The following is a description of a gene set: from publication Wakim LM, Woodward-Davis A, Liu R, Hu Y, Villadangos J, Smyth G, Bevan MJ (PMID 22922816) Genes down-regulated in memory CD8 T cells: ITGAE- from spleen versus ITGAE+ from brain. Tissue resident memory (Trm) represent a newly described memory T cell population. We have previously characterized a population of Trm that persists within the brain following acute virus infection. Although capable of providing marked protection against a subsequent local challenge, brain Trm do not undergo recall expansion following dissociation from the tissue. Furthermore, these Trm do not depend on the same survival factors as the circulating memory T cell pool as assessed either in vivo or in vitro. To gain greater insight into this population of cells we compared the gene-expression profiles of Trm isolated from the brain to circulating memory T cells isolated from the spleen following an acute virus infection. Trm displayed altered expression of genes involved in chemotaxis, expressed a distinct set of transcription factors and overexpressed several inhibitory receptors. Cumulatively, these data indicates that Trm are a distinct memory T cell population disconnected from the circulating memory T cell pool and displaying a unique molecular signature which likely results in optimal survival and function within their local environment. species: Homo sapiens Human Gene Set: GSE39152_SPLEEN_CD103_NEG_VS_BRAIN_CD103_POS_MEMORY_CD8_TCELL_DN, and this is the list of marker genes: MAFF (MAF bZIP transcription factor F), MEOX1, RNF44, CD99, BSN, IGLL1, LTBP2 (NCBI Gene Id 83981), CACNG1, ZFP28, KCNK1, FZD2, C11orf16, PLA2G5, APOC4, KARS1, PTGDR, ZNHIT3, POU2F2, PEG3, FHIT, NDUFS4, MMP11, PDCD7, ATP6V1B2, C4BPA, TNNI1, SFRP2, ATOH1, DHCR24, MAPK10, LRIG1, ATXN1, SSTR5, RNF6, FBXW4, CSTF1, TEF, PFN2, FOXO3, SART3, CEBPA, PHEX, RRAD, CD276, SLC6A12, SFTPB, XPC, LRP1, HOXA9, TMEM45A, EPB41, ZNF740, ZFPM2, NR2F6, ATP7B, IAPP, ELK4, ARHGAP39, UNC119, C9, PSENEN, GPR19, THAP4, MAP1LC3A (NCBI Gene Id 84557), ANKRD46, KRT86, ESRRA, ZNF467, SCG2, SCN3A, B3GALT1, FJX1, RNF220, RYR3, FAM151A, PNKD, PIK3C2G, SERPINA1, AAMP, CD28, KRT31, PROM1, ACE (angiotensin I converting enzyme), KYAT3, TFF2, FEZ1, CKAP4, ERLIN1, TWF2, EPHA8, DUSP6, GPX3, TYRO3, COX6A2, BMP7, INHA, NAA11, TAC3, ALDH1A3, GTF2I, IFT46, CLIP1, RXRA, CAPN6, EFNA3, USF1, TK2, CRYGC, ZSCAN2, ITIH3, TOMM34, SPRY4, DNAJB13, ABL1, COL8A1, FZD4, ATP1B1, PAQR7, LHB, SLC6A13, MARVELD1, CHRD, WBP1, MPV17 (mitochondrial inner membrane protein MPV17), PPT1, SLC50A1, PTDSS2, DNASE1L3, VAX1, YPEL3, SLC6A18, C3AR1, COL1A1, LYST, MCEE, COLGALT1, RELL1, SCMH1, PLD3, GABARAPL1, NR1D1, KRT15, ADCY9, GRIN1, FOXQ1, CACNA2D1, TEX2, COL4A2, KCNA5, GGCX, MBP (myelin basic protein), H2BC5, KLHL21, CFB, DENND4C, TCF3, USP29, PEF1, PER1, RPL31, SQSTM1, CPA3, PSPN, REL, NUDC, SYNRG, CYP21A1P, FADS1, PTPRE, TTC14, MTFR1L, SH2B1, SMIM20, CDSN, CDC23, CLIP3, INSM1, TCIRG1, MRTFA, TBC1D10A, RASAL1, GTSE1, MVK, CA8, RGS6, ARL4D, ACKR1, LYL1, SEZ6, AMPD3, STAG1, WNT10A, CORO2B, ZNF394, PPEF2, FIGNL1, UVRAG, TLE1, TSPO2, SCN7A